Given this list of marker genes TTC27, CCDC106, ZNF608, MRPL38, METTL26, CD22, ZIK1, FAM177B, SNX22, ARHGEF10, DVL1, CACTIN, AHRR, ZNF502, FAM24B, ZNF880, GADD45GIP1, VPREB3, LRWD1, ACSF3, MLST8, KRI1, ATP13A4, FAM30A, CEP295, PKIG, NEK8, GTF2H4 (general transcription factor IIH subunit 4), CENPV, MTA1, LIG1, here is a description of the gene set: from publication Ovsyannikova IG, Oberg AL, Kennedy RB, Zimmermann MT, Haralambieva IH, Goergen KM, Grill DE, Poland GA (PMID 27441275) Human Gene Set: OVSYANNIKOVA_PBMC_FLUARIX_AGE_55_64YO_RESPONDERS_VS_NONRESPONDERS_0DY_UP Genes up-regulated in peripheral blood mononuclear cell responders vs nonresponders in adults (55-64) after exposure to Fluarix, time point 0D. Comment: Gene expression related to HAI response To assess gene signatures related to humoral response among healthy older subjects following seasonal influenza vaccination, we studied 94 healthy adults (50-74 years old) who received one documented dose of licensed trivalent influenza vaccine containing the A/California/7/2009 (H1N1)-like virus strain. Influenza-specific antibody (HAI) titer in serum samples and next-generation sequencing on PBMCs were performed using blood samples collected prior to (Day 0) and at two timepoints after (Days 3 and 28) vaccination. We identified a number of uncharacterized genes (ZNF300, NUP1333, KLK1 and others) and confirmed previous studies demonstrating specific genes/genesets that are important mediators of host immune responses and that displayed associations with antibody response to influenza A/H1N1 vaccine. These included interferon-regulatory transcription factors (IRF1/IRF2/IRF6/IRF7/IRF9), chemokine/chemokine receptors (CCR5/CCR9/CCL5), cytokine/cytokine receptors (IFNG/IL10RA/TNFRSF1A), protein kinases (MAP2K4/MAPK3), growth factor receptor (TGFBR1). The identification of gene signatures associated with antibody response represents an early stage in the science for which further research is needed. Such research may assist in the design of better vaccines to facilitate improved defenses against new influenza virus strains, as well as better understanding the genetic drivers of immune responses. studied in species Homo sapiens